Given this list of marker genes CHMP1B, RAB11A, CHMP5, ANXA8, DNM1, FHIP1B, VPS4B, ANXA8L1, VPS37B, UBR4, EEA1, RILP, PI4K2B, PRKN, PIK3C3, ATP6AP2 (NCBI Gene Id 95880), CLCN3, VPS11, SQSTM1, WASH3P, VPS4A, UBAP1, USP50, PLEKHA3, VAMP4, PDCD6IP, MICALL2, VTA1, CORO1C, CHMP7, SNX3, ATP6V0B, TSG101, TMEM9, USP8, ATP6AP1, TOM1, SNF8, PLEKHF2, VPS33B, ARFGEF2 (ADP ribosylation factor guanine nucleotide exchange factor 2), ATP6V1H, SYNJ1, EXOC8, SNX33, PI4K2A, TMCC1, ALS2, LAMTOR1, HOOK1, HOOK3, STAM2, VPS36 (NCBI Gene Id 51028), RAB7A, PLEKHJ1, RNF26, ATP6V1F, ATP6V0C (NCBI Gene Id 527), CHMP6, PLEKHF1, VPS37C, STX6, CHMP2B, DNAJC13, RAB27A, VPS25, CHMP2A, RNASEK, LAPTM4B, VPS28, FASLG, VPS37D, SCARB2 (NCBI Gene Id 950), VPS18, HGS, MVB12B, SNX10, ATP6V0A1, PHETA2, ATP6V1D, RAB22A, VPS37A, AQP11 (NCBI Gene Id 282679), RAB5C, WASHC4, MVB12A, AKTIP, TMEM127 (transmembrane protein 127), CHMP4A, CHMP1A, CHMP3, IST1, HOOK2, CHMP4B, STAM, PHETA1, RAB5B, CHMP4C, WASHC5, ATP6V1A, CC2D1A, here is a description of the gene set: Human Gene Set: GOBP_ENDOSOME_ORGANIZATION A process that is carried out at the cellular level which results in the assembly, arrangement of constituent parts, or disassembly of endosomes. species: Homo sapiens